The following is a description of a gene set: Any cellular metabolic process involving deoxyribonucleic acid. This is one of the two main types of nucleic acid, consisting of a long, unbranched macromolecule formed from one, or more commonly, two, strands of linked deoxyribonucleotides. Mouse Gene Set: GOBP_DNA_METABOLIC_PROCESS species: Mus musculus, and this is the list of marker genes: Cbx8, Top2b, Bcl6, Nfic, Cinp, Usp51, Fmn2, Sycp3, Taf6l (NCBI Gene Id 75618), Fbxo4, H1f10, Jmy, Ung, Jade3, Neil1 (NCBI Gene Id 72774), Kmt5c, Setx, Xab2, Mdc1, Xrcc4, Rfc2, Nscme3l, Dkc1, Il4, Vps54, Slf2, Ptk2b, Polb, Pfn1, Tfpt, Stra8 (NCBI Gene Id 20899), Polrmt, Meioc, Dctpp1, Gli2, Dtl, Msh5, Smc5, Rad51d, Wapl, Kctd13, Actr5, Wiz, Il27ra, Nbn, Htr2a, Cdc14b, Huwe1, Polg, Gtf2h2, Sp100, Smarcd2, Mpg, Cdc7, Kat7 (NCBI Gene Id 217127), Neil2, Cfh, Mutyh, Pou5f1, Rif1, Crhr2, Rnaseh1, Mtnap1, Faap20, Orc4, Nmnat1, Atg7, Spire1, Polh, Exosc6, Ino80c, Zbtb38, Orc3, Pdgfa, Terf1, Fgf10, Gins3, Spidr, Cdk1, Taok1, Morf4l1, Dntt, Smarcd3, Exosc3, Nudt16l1, Tert, Nhp2 (NHP2 ribonucleoprotein), Ogg1, Stox1, Ppp4r2, Tnks, Rnaseh2c, Nfrkb, Fgfr4, Prkcd, Taf10, Rec8, Neurl4, Mrnip, Ing5, Ssrp1 (structure specific recognition protein 1), Aen, Hdac9, Parp9 (poly (ADP-ribose) polymerase family, member 9), Dscc1, Banf1, Pcna, Cyren, Terf2, Tnf, Rad51, Lef1, Tcf7l2, Pole3, Hsf2bp, Recql5, Nthl1, Cul4a (cullin 4A), Dnase1l1, Chd1l, Mir181b-1, BC037156, Hinfp, Cdk9, Ppp4r3a, Smarcb1, Hpf1, Lmna, Slf1, Exo5, Carm1, Htatsf1, Msh3, Gtf2h3, Mad2l2, Parpbp, Ylpm1, Fzr1, Bod1l, Rad18, Mcm4, Lin9, Asf1a, Setd2, Ptprc, Sirt6, Chtf18, Zranb3, LTO1, Sprtn, Rpa3, Camk2d, Pgbd5, Hmgb1, Pole2, Chaf1a, Nono, Pld3, Nfkbiz, Axin2 (axin 2), Tet3, Actl6a, Fancg, Naf1, Tmem161a, Kdm2a, Dcaf1, H1f6, Ube2v2, Tcf3, Kmt5b, Commd1, Hnrnpd, Taf9, Ezh2 (NCBI Gene Id 14056), Nasp, Ankrd17, Atm, Dot1l, Cdkn2a, Pinx1, Sin3a, Gata5, Smc6, Mcm5, Rnf168, Eny2, Pdgfb, Hgf, Fam168a, Map2k7, Ubr5, Endov, Smg1, Spdya, Yeats4, Sem1, Mcm3, Il2, Ssbp1, H1f1, Fbxo5, Nsd2, Tnp1, Primpol, Rad51ap1, Ankle1, Icosl, Rfc1, Paxip1, Ercc6l, Tet1, Ticrr, Mapk15, Ep400, Dnaja3, Supt7l, Zmynd8, Bcl11b, Gzma, Pms2, Ppp4r3c2, Prkcg, Ube2a, Fan1, Cyp1b1, Tnfsf4, Radx, Cct5, Hdgfl2, Cst3, Ube2b, Nabp1, Rnf212b, Rnf169, Actr8, Rad21, Fhit, Usp47, Syncrip, Smc1a, Ccne1, Kat2a, Dpf1, Pbrm1, Fanca (Fanconi anemia, complementation group A), Kmt5a, Cdk2, Uchl5, Sesn2 (sestrin 2), Msh6, Tdp2, Poln, Gli1 (NCBI Gene Id 22705), Chchd4, Rad1, Smarcd1, Ube2w, Nppc, Lrwd1, Brca2, Sfpq, Brd7, Trrap, Xrn2, Cdk7, Dcp2, Cdkn2d, Ercc2, Pak3, Tex264, Ercc8, Mpnd, Smg6, Cntd1, Chaf1b, Shld2, Rbbp7, Prim1 (NCBI Gene Id 19075), Zfp830, Exosc10, Ggn, H1f5, Mcm10, Eya3, Kdm1a, Swi5, Sub1, Ube2n, Dtd1, Ruvbl1, Otub1 (OTU domain, ubiquitin aldehyde binding 1), Ercc1, Recql, Tcp1, Trip13, Nox4, Supt20, Swap70, Nfia, Prpf19, Hspd1, Pold2, Egfr, Hrob, Stub1, Ppp1ca, Hnrnpab, Actr2 (actin related protein 2), Kin, Smarce1, Gnl3, Clspn, Adra2a, Akt1, Parp1, Twist1, Fancl, Vcpip1, Polq, Rpain, Nynrin, Aicda, A1cf, Tk1, Ddx39b, Setmar, Pds5a, Hspa1a, Prim2, Rbbp6, Morf4l2, Pias4, Taf5, Uvssa, Ctc1, Rmi2, Herc2, Bend2, Dmc1, Pld4, Nek2, Trpc2, Chrna4, Ino80, Ptges3, Rnf111, Rnf212, Terb2, Mcmbp, Mapk3, Trp53bp1, Rpa2, Tdg, Tspyl2 (TSPY-like 2), Spata22, Noc3l, Cd28, Mlh3, Nfix, Brpf3, Mcm7, Pole, Vps72 (vacuolar protein sorting 72), Nsmce2, Map2k4 (mitogen-activated protein kinase kinase 4), Sfr1, Orc2, Uhrf1, Potefam3a, Jun, Rexo2, Bccip, Ppp4c, Usp1, Ahr, Cdadc1, Gnl3l, Pold1, Atxn7l3, Kat5 (K(lysine) acetyltransferase 5), Dnajc2, E2f7, Swsap1, Morc2b, Atf1, Phb1, Apaf1 (NCBI Gene Id 76129), Ankrd66, Xrcc1, Psme4, Prkcq, Rnf8, Nme3, Nudt15, Shld3, Xrn1 (NCBI Gene Id 97523), Tada1, Ttf2, Faap24, Dusp1, Supt16, Dyrk1b, Trp53, Niban2, Met, Eepd1, Spo11, Sh2b1, Pkib (NCBI Gene Id 19081), Mms19, Bcl7a, Vegfa, Peli1, Ube2d3, Rev1, Brd8, Map3k4, Hfm1, Ndfip1, Tbrg1, Tfrc, Cgas, Pola1, E2f8, Dhx36, Pml, Ttc5, Anxa3, Ccna2, Tnks2, Nop10, Abraxas1, Pds5b, Cdkn1a, Cct3, Fbh1, Parn, Mcidas, Rad52, Senp2, Hmga1b, Fmr1, Cct4, Csnk2a1 (NCBI Gene Id 12999), H2ac25 (NCBI Gene Id 319162), Cep164, Ddx11, Ppp4r3c1, Tnks1bp1, Poldip2, Rec114, Etaa1, Fen1, Dffa, Smarcc1, Rac1, Gtf2h5, Prkd2, Twnk, Il6, Tgfb1, Tent4b, Skp2, Adprs, Supt6, Helq, Sirt7 (NCBI Gene Id 209011), Ints3 (NCBI Gene Id 97059), Pold3, Brcc3, Shoc1, Hltf, Smarca5, Dpf3, Setd7, Fignl1, Fancm, Nuggc, Pogz, Ddb2, H1f9, Spire2, Foxp1, Fbxo6, Hormad1, Babam1, Rad50, Apobec1, Dclre1c, Bach1, Foxl2, Ercc4 (NCBI Gene Id 50505), Zpr1, Usp37, Cbs, Msh4, Mbtd1, Tdp1, Clcf1, Smc4, Dhx9 (NCBI Gene Id 98320), Timeless, Baz1a, Mms22l, Dclre1b, Lrrc34, Pagr1a, Taf12, Smc2, Tnfsf13, Alkbh1, Rrm2b, Esco2, Pif1, Actb, Trip12, Gins4, Kcnk2, Dmap1, Cd40, Khdc3, Ube2v1, Nop53, Zbtb7a, Slx4, Chd4, Lig3, Atxn7, Brcc3dc, Palb2, Rfc5, Rad51c, Dbf4, Sirt1, Polr2i, Ddb1, Rfwd3, C3ar1, Cct7, Shld1, Hmga1, Inppl1, Smc3, Prkdc, Fto, Tnfaip1, Xpc, Polk, Dnase1l2, Rad9a, Dclre1a, Ing4, Npas2, Hnrnpc, Kdm4d, Dnase1l3, Hsp90aa1, Nipbl, Cep63, C1qbp, Ap5z1, Ankrd1, Zscan4d, Rmi1, Rad23b, Chrac1, Hmgb2, Atrip (ATR interacting protein), Taok3, Smarca4, Isg20, Gmnc, Hmgn1, Actl6b, Rag2, Suv39h1, Xrcc5, Cd40lg, Foxm1, Aifm1, Gch1, Cacybp, Ankrd31, Ccne2, Pola2, Taf7, Ifng, Ccdc117, Cct6a, Tbx21, Nsmce1, Ufl1, Eya2, Mir181b-2, Smoc2, Rnf138rt1 (ring finger protein 138, retrogene 1), Sf3b5 (NCBI Gene Id 66125), Vcp, Acd, Smarcc2, Mnd1, Park7, Terb1, Tcf7, Stn1, Cnbp, Hsf1, Ager, Epc2, Mcrs1, 4930447C04Rik, Shprh, Mrgbp, Rexo4, Nek7, Cdc6, Gins1, Ptges3-ps, Ing3, Mta1, Ucn, Dach1, Tex11, Bard1, Wrap53, Fgfr1, H1f4, Gmnn, Brip1, Zfp668, Tfdp1, Recql4, Faf1, Meaf6, Mcmdc2, Hsp90ab1, Usp9x, Ccr6, Mapk8, Pnp, Xrcc6, Epc1, Prmt6, Zgrf1, Parp3, Blvra, Samhd1, Esco1, Plk1, Fh1, Dnase2a, Usp45, Top1mt, Apobec3, Wdhd1, Chek2, Tada3, Zcwpw1 (zinc finger, CW type with PWWP domain 1), Jade1, Nme1, Ubr2, Pot1a, Phf10, Csnk2a2, Pot1b, Top3b, Fgf2, Pold4, Jade2, Fancb, Arrb2, Meiob, Supv3l1, Riox1, Hnrnpa2b1, Polm, Trex1, Uimc1, Cdc42, Dynll1 (NCBI Gene Id 56455), Usp22, Ascc1, Alkbh2, Smpd3, Wnt3a, Neil3, Stat6, Cenps, Iffo1, Rps3, Alkbh3, Xrcc2, Apbb1, Exosc4, Src, Yy1, Top6bl, Potefam3b, Apex2, Phf13, Apex1 (NCBI Gene Id 11792), Hras, Ctnnb1, Rgn, Parp2, Fancf, Arid1a, Ap5s1, Terc, Rtel1, Dpf2, Uvrag, Polg2, Hmga2, Ten1, Taf2, Kash5, Tigar, Cebpg, Usp28, Fancc (Fanconi anemia, complementation group C), Tdrd3, Lpin1, Terf2ip, Pdgfrb, Lig4, Syce3, Bcl7b, Rbbp4, Slc15a4, Stk19 (NCBI Gene Id 54402), Orc5, Rad17, Ercc3 (excision repair cross-complementing rodent repair deficiency, complementation group 3), Pnkp, Aptx, H2ax, Upf1, Cct8, Parp10, Pms1, Mettl4, Lox, Zscan4f, Hdac10, Tonsl, Id3, Tdg-ps, Tk2, Hmces, Rad51b, Rbx1, Top1, Pcyt1a, Ascc3, Mcm6, Zswim7, Rnaseh2b, Brca1, Npm1, Ccnb1ip1, Nabp2, Aste1, Cdc5l, Klf4, Atr, Ino80b (NCBI Gene Id 70020), Gstt1 (NCBI Gene Id 14871), Nfatc1, Oga, Gtf2h4, Batf, Parp4, H1f2, Igf1r, Mc1r, Pwwp3a, Rtf2, Trex2, Exo1, Rev3l, Zscan4c, Rad23a, Ppp4r3b, Mei4, Foxp3, Tet2, Ehmt2 (euchromatic histone lysine N-methyltransferase 2), Mre11a, Ilkap, Nvl, Ino80e, Hus1b (HUS1 checkpoint clamp component B), Rag1, Chtf8, Adipoq, Cdt1 (NCBI Gene Id 97441), Ercc6, Igfbp3, Chek1, Ubqln4, Sanbr, Topbp1, Ube2t, Dicer1, Gfer, Zbtb1, Rnf138, Rgcc, Crebbp, Donson, Poli, Pttg1, Myc, Sgf29, Fus, Sphk1, Exd2, Fbxw7, Smarcad1 (NCBI Gene Id 13990), Exosc5, Exog, Inip, Firrm, Wdr18, Rnaseh2a, Cul4b, Tipin, Xpa, Nfib, Sde2, Rrm1, Gen1, Poll, Taf6, Mpv17, Usp10, Dna2 (NCBI Gene Id 327762), Ascc2, Aplf, Kif22, Ino80d (INO80 complex subunit D), Dnase1, Nudt1, Rad21l, Ttf1, Rny1, Rny3, Smg5, Xrcc3, Tep1, Ooep, Nat10, Senp3, Psmc3ip, Sycp1, Cidea, Ier3, E4f1, Eya4, Orc1, Cetn2, Zfp365, Aunip, Bcl7c, Smarcal1, Smchd1, Hmbox1, Otud4, Gsk3b, Rad54b, Cct2, Marf1, Brme1, Obi1, Pam16, Faap100, Nucks1 (nuclear casein kinase and cyclin-dependent kinase substrate 1), Nsmce3, Rfc3, Zfp827, Trim28, Ddx1, Pura, Rhno1, Rad54l, Usp3, H1f3, Bax, Emsy, Slx1b, Nsmce4a, Mnat1, Mcm2, Prmt1, Helb, Dtx3l, Dnase2b, Mapkapk5, Npm2, Eme1, Ercc6l2, Gar1, Rad9b, Zfyve26, Hnrnpu, Tex19.1, Mgmt, Dffb, Rpa1, Gin1, Ciz1, Atad5, Endog, Top2a, Msh2, Gtf2h1, 1700028K03Rik, Mcm8, Hus1, Lig1, Nhej1, Smug1, Wrnip1, Grwd1, Gins2, Cdca5, Tex12, Smarca2, Mus81, Prdm9, Majin, Cdc45, Rfc4, Aurkb, Was, Kat2b, Blm, Tinf2, Fancd2, Mapk1, Cenpx, Rbms1, Eid3, Bmyc, Klhl15, Abl1, Top3a, Iho1, Ruvbl2, Ppp1r10, Gja1, Taf5l, Eme2, Atrx, Ercc5, Ereg, Orc6, Dek, Mgme1, Fanci, Egf, Usp7, Hcrt, Pole4, H1f8, Ccn2, Traip, Rbbp8 (retinoblastoma binding protein 8, endonuclease), Arid2, Eya1, Enpp7, Zbtb48, Mcm9, Zmpste24 (zinc metallopeptidase, STE24), Hdac8, Pclaf, Wdr48, Gtpbp4, Fam111a, Mlh1, Sf3b3, Rnf126 (NCBI Gene Id 70294), Tex15, Babam2, Parg (NCBI Gene Id 26430), Aktip, H1f0, Mas1, Macroh2a1, Mbd4, Paxx, Wrn, Psmd14